The following is a description of a gene set: IL10 family to Jak-STAT signaling pathway. Pathway ID: N00415. Pathway type: Reference. Pathway class: nt06518 JAK-STAT signaling. studied in species Homo sapiens Pathway Definition from KEGG: (IL10,IL19,IL20,IL22,IL24,IL26) -> ((IL10RB+(IL10RA,IL20RA,IL22RA1)) -> (JAK1+TYK2) -> STAT3 Human Gene Set: KEGG_MEDICUS_REFERENCE_IL10_FAMILY_TO_JAK_STAT_SIGNALING_PATHWAY, and this is the list of marker genes: IL22RA1, IL26, IL20, IL10, TYK2, IL10RA, IL20RA, JAK1, IL10RB, STAT3, IL19, IL24, IL22